Given this list of marker genes Has3, Nfkb1, Chpf, Csgalnact1, Hs3st2, Slc35b2, Hs3st3a1, Galnt3, Chst7, Chsy1, Xylt1, B3gnt8, Egf, Csgalnact2, Ext1, Ptger4, Hs3st1, Pxylp1, B3galt6, Cytl1, B3gnt2 (NCBI Gene Id 85024), B4galt5, Tgfb1 (transforming growth factor, beta 1), Ap2a1 (NCBI Gene Id 11771), Cltc, Chsy3, B3gnt4, Chpf2, Abcc5, Chst13, B4galnt4, B3gnt9, B3gnt3, Igf1, Hs3st3b1, B3gat1, Ugdh, Ndst2, Xylt2, Has1, B4gat1, B3gnt7, Pdgfb, Chst11, Pdgfrb, Chst3, Dse, B3gat3 (beta-1,3-glucuronyltransferase 3), Chst12, Il1b, Smpd3 (NCBI Gene Id 80691), B4galnt3, B3gnt6, B4galt7, Ext2, Slc35d1, Ccnd3, Hyal1, Hexa, Has2, B3gat2, here is a description of the gene set: The chemical reactions and pathways resulting in the formation of aminoglycans, any polymer containing amino groups that consists of more than about 10 monosaccharide residues joined to each other by glycosidic linkages. Mouse Gene Set: GOBP_AMINOGLYCAN_BIOSYNTHETIC_PROCESS species: Mus musculus